Given this list of marker genes SIX3, STRA6, KMT2D, TXNDC15, CIROP, ZIC3, PLD1, NODAL (NCBI Gene Id 8114), NSDHL, KDM6A, PLXND1, MAPKAPK5, GDF1, here is a description of the gene set: Human Gene Set: HP_SINGLE_VENTRICLE Single ventricle The presence of only one working lower chamber in the heart, usually with a virtual absence of the ventricular septum and usually present in conjunction with double inlet left or right ventricle. studied in species Homo sapiens